The following is a description of a gene set: Mouse Gene Set: GOBP_POSITIVE_REGULATION_OF_HUMORAL_IMMUNE_RESPONSE_MEDIATED_BY_CIRCULATING_IMMUNOGLOBULIN studied in species Mus musculus Any process that activates or increases the frequency, rate, or extent of a humoral immune response mediated by circulating immunoglobulin., and this is the list of marker genes: Tnf, Gimap5, Lta, Trem2, Fcer2a, Nod2, Gimap3, Hpx, Ptprc